Given this list of marker genes DNASE2, PIK3R1, PTEN, SH2D1A, XIAP, PIK3CD, here is a description of the gene set: Human Gene Set: HP_SEVERE_EPSTEIN_BARR_VIRUS_INFECTION species: Homo sapiens An unusually severe Epstein Barr virus (EBV) infection. Severe Epstein Barr virus infection